Given this list of marker genes TEX11, SYCE3, DDB1, TOPAZ1, YBX3, BCL2, CASP2 (NCBI Gene Id 835), UNC5C, DNASE1L3, UBE2B, FGF2, KITLG, BAX, CNTF, NTRK1, MAEL, FASLG, KIT, PRKDC, SOD1 (NCBI Gene Id 6647), IL1B, IL1A, SYCP2, TMEM215, BCL2L1, here is a description of the gene set: The activation of endogenous cellular processes that result in the death of a cell as part of its development. studied in species Homo sapiens Human Gene Set: GOBP_PROGRAMMED_CELL_DEATH_INVOLVED_IN_CELL_DEVELOPMENT